The following is a description of a gene set: studied in species Homo sapiens Botulinum toxin type E (botE, also known as BoNT/E), a disulfide-bonded heavy chain (HC) - light chain (LC) heterodimer (“dichain”), enters the gut typically as a result of consuming contaminated food, as a complex with nontoxic nonhemagglutinin protein (NTNHA, encoded by the C. botulinum ntnha gene). The complex protects the toxin from degradation in the gut and mediates its association with the gut epithelium and transcytosis to enter the circulation. Circulating toxin molecules associate with gangliosides and synaptic vesicle protein 2 (SV2) exposed by exocytosis at a synapse of a target neuron. Vesicle recycling brings the toxin into the neuron where the vesicle is acidified. The lowered pH induces a conformational change in the toxin: its HC forms a passage in the vesicle membrane through which its LC is extruded into the neuronal cytosol and released by reduction of the HC - LC disulfide bond. The LC then catalyzes the cleavage of synaptosome-associated protein 25 (SNAP25) on the cytosolic face of the neuronal plasma membrane, thereby inhibiting synaptic vesicle fusion with the plasma membrane and exocytosis. part of: Neurotoxicity of clostridium toxins Reactome Pathway: Toxicity of botulinum toxin type E (botE), and this is the list of marker genes: SV2B, ntnha, SV2A, botE, SNAP25